The following is a description of a gene set: Glycosphingolipid biosynthesis Human Gene Set: REACTOME_GLYCOSPHINGOLIPID_BIOSYNTHESIS studied in species Homo sapiens, and this is the list of marker genes: B4GALNT1, GAL3ST1 (NCBI Gene Id 9514), UGT8, ST8SIA5, A4GALT, ST6GALNAC5, FUT1, ST3GAL5, ST3GAL3, B4GALT5, B3GNT5, B4GALT6, B3GALNT1 (beta-1,3-N-acetylgalactosaminyltransferase 1 (Globoside blood group)), UGCG (NCBI Gene Id 7357), ST3GAL2, B3GALT4, CERK, FUT2, ST6GALNAC6